The following is a description of a gene set: Human Gene Set: HP_KNEE_CONTRACTURE Lack of full passive range of motion (restrictions in flexion, extension, or other movements) of the knee joint resulting from structural changes of non-bony tissues, such as muscles, tendons, ligaments, joint capsules and/or skin. species: Homo sapiens Knee contracture, and this is the list of marker genes: DPM1, TRPV4, FBN1, LMNA, GJB6, SCARF2, SVIL, HS2ST1, COL6A2, CNTNAP1, ALG2, SELENON, ERLIN2, COX11, SDHA, BICD2, ATP6V1E1, NEDD4L, ESCO2, CHRNG, MYL11, PIEZO2, COL6A1, GMPPB, PLOD2, ITGA7 (integrin subunit alpha 7), C19orf12, EMD, GNPTAB, LMBRD2, MEGF8, FBN2 (fibrillin 2), GFPT1, NT5C2, TPM3, DPAGT1, LMX1B, COL25A1, MAP3K20, MYL1, PSTPIP1, SCYL2, RNU4ATAC, UFC1, HACD1, PSAT1, KAT6B, ALG14, MYH3, TPM2, PTDSS1, MYL2, SLC18A3, FKBP10, FLNA, ADAMTS15, GLI3, SLC39A8, CHRNB1, LIFR, COG8, SDHD, COL6A3, RTTN (NCBI Gene Id 284278), SCN4A, ERCC1, PIK3R2, CFL2, DDR2, GJB2, ERCC6, SIK3, UBA1, UNC80, NALCN, GNPAT, FHL1, LGI4, NFATC2, SDHAF1, TAF4, SYT2, ERGIC1, SLC25A46, JAG2, KY, PTH1R, TELO2, PIGA, DHX16, ANKLE2, RPL10, MEGF10, ACTA1, SNAP25, ERLIN1, PIGY, LBR, STX5, SDHB, ZBTB20, COL12A1, FILIP1, SRD5A3, GNB2, DMD, CPT2, PI4KA, MYO9A, TRIM2, BAG3, FDFT1